Given this list of marker genes TRIM32, IL17F, IKBKE, TRAF5, NOTCH1, TRAF3IP2, TRAF6, IL17RA, IL17A, USP25, TRAF2, MIR135A1, SRSF1, here is a description of the gene set: The series of molecular signals initiated by interleukin-17 binding to its receptor on the surface of a target cell, and ending with the regulation of a downstream cellular process, e.g. transcription. species: Homo sapiens Human Gene Set: GOBP_INTERLEUKIN_17_MEDIATED_SIGNALING_PATHWAY